Given this list of marker genes BPHL, AOC4P, FYTTD1P1, SLCO1B7, BDH1, DPYS, HGD (homogentisate 1,2-dioxygenase), ITIH4, HAO1, LINC00616, NPSR1-AS1, APOC4, UGT2B27P, ENSG00000233569, RN7SL583P, FOLH1B, LINC01344, PFKFB1, CNGA1, SLC22A9, TDRD15, RPL23AP6, APOA5, GLS2, SPP2, ALDH1L1, NKX2-8, ACSM2A, CCT8P1, THPO, AKR1D1, SLCO4C1, SLC39A14, HACD2 (NCBI Gene Id 9199), LINC01717, CAPN12, MFFP1, APOC2, LINC02027, PC (pyruvate carboxylase), SLC17A1, BPIFB2, WNK4, CA5A (carbonic anhydrase 5A), SLC22A25, GBP7, SLC17A2 (solute carrier family 17 member 2), SHBG, HAL, LIPC, CFHR4, ANG, ACSL3P1, GPAM, HPD, AGXT2, STEAP2-AS1, TMEM82, ABCC6, A1BG, ABCC2, HISLA, PON1, MT1B (NCBI Gene Id 81836), CPB2, KLKB1, NUGGC, LINC03064, CBS, AGMO, SLC51A, LPAL2, CYP3A43, LINC02607, ENSG00000201368, ASS1, GCKR, PSMC1P9, G6PC1 (glucose-6-phosphatase catalytic subunit 1), LIPC-AS1, NAT8, ACSS2, GYS2, PROZ, DPYD-IT1, GAS2, HPR (NCBI Gene Id 3250), AKR1C1, SMAD3-DT, GLYATL1, ENSG00000250493 (novel transcript, antisense to GRIK4), HSD17B7, CASC19, PTP4A1, SNAP25-AS1, GPC5, RPS3AP54, PLCXD2, SLC22A24, AFMID, KLB, LINC02499, SLC2A9, LINC00907 (NCBI Gene Id 284260), OXT, ENSG00000228697, LINC01900, ACOT12, ACMSD, ABCB11, APOC1P1, SLCO1B3, NR1I3, UROC1, SLC22A7, PANK1, MIR122HG, LINC02919, GLYAT, CCDC73, CPS1, ABCG5, SLCO1B1, CPN1, RHBG, F11, here is a description of the gene set: from publication Cao J, O'Day DR, Pliner HA, Kingsley PD, Deng M, Daza RM, Zager MA, Aldinger KA, Blecher-Gonen R, Zhang F, Spielmann M, Palis J, Doherty D, Steemers FJ, Glass IA, Trapnell C, Shendure J (PMID 33184181) Human Gene Set: DESCARTES_MAIN_FETAL_HEPATOBLASTS species: Homo sapiens Marker genes curated from the annotated cluster as represented in the Descartes Human Gene Expression During Development database. The gene expression program underlying the specification of human cell types is of fundamental interest. The study authors generated human cell atlases of gene expression and chromatin accessibility in fetal tissues. For gene expression, the study authors applied three-level combinatorial indexing to >110 samples representing 15 organs, ultimately profiling ~4 million single cells. The study authors leveraged the literature and other atlases to identify and annotate hundreds of cell types and subtypes, both within and across tissues. Our analyses focused on organ-specific specializations of broadly distributed cell types (such as blood, endothelial, and epithelial), sites of fetal erythropoiesis (which notably included the adrenal gland), and integration with mouse developmental atlases (such as conserved specification of blood cells). These data represent a rich resource for the exploration of in vivo human gene expression in diverse tissues and cell types.